The following is a description of a gene set: from publication Szanto A, Balint BL, Nagy ZS, Barta E, Dezso B, Pap A, Szeles L, Poliska S, Oros M, Evans RM, Barak Y, Schwabe J, Nagy L (PMID 21093321) studied in species Homo sapiens Genes up-regulated in bone marrow-derived macrophages with STAT6 knockout treated with rosiglitazone: control versus IL4. C57Bl/6 wild-type and STAT6 KO mice were used to study PPARg and IL-4 signaling. Bone marrow of 3 mice per group was isolated and differentiated to macrophages with M-CSF (20 ng/ml). 20 ng/ml IL-4 was used to induce alternative macrophage activation and 1 uM Rosiglitazone (RSG) was used to activate PPARg. From each mouse 4 samples were generated: 1. M-CSF, 2. M-CSF+RSG, 3. IL-4 and 4. IL-4+RSG. All compounds were added throughout the whole differentiation process, and frech media was added every other day. Control cells were treated with vehicle (DMSO:ethanol). After 10 days, RNA was isolated and gene expression profiles were analyzed using Mouse Genome 430 2.0 microarrays from Affymetrix. Human Gene Set: GSE25088_ROSIGLITAZONE_VS_IL4_AND_ROSIGLITAZONE_STIM_STAT6_KO_MACROPHAGE_DAY10_UP, and this is the list of marker genes: PGAP6, SYK, TLE4, PARP16, TGFBR2, CAMK1D, ENSG00000284948, CLCN4, PGGHG, KMT2D, ARHGAP19, FKBP8, DNAAF11, DGCR2, HAL, TBXAS1, ARSG, BAZ2B-AS1, REPS2, TRAPPC14, FOLR1, PAIP2, TBC1D10C, RAB43, H2AC11, FURIN, AOC3, YPEL5, TMEM91, UBXN2B, NUP50, ZDHHC18, MAP3K1, VSIR, ZFP36L2, RAF1, RNF44, TNRC18, RYBP, TIMP2, RNASE2, WIPI2, TAGLN2 (NCBI Gene Id 8407), MTMR3, CCDC28A, PPP1R12A, IFITM2, TRIM25, STX16, IQGAP1, DEF8, NFAM1, NHSL2, F5, NT5C3A, GNAS, MAPK1, ADGRE3, TLR8, CELF2, MARF1, SMARCA2, TRPM6, NCOA4, DEF6, TOB2, PCMTD1, LRCH4, TRERF1, TAOK3, TNRC6B, MAP3K2, PPP1R12B, ZNF93 (NCBI Gene Id 81931), NAIP, ARAP3, KIT (KIT proto-oncogene, receptor tyrosine kinase), RUBCNL, ZNF641, XKR8, KRT23, MTURN, SCAP, ARPC5, TMT1A, HYCC2, NDEL1, GLIPR1, MAN2A2, SNX18, LAMTOR4, PADI4, RXRB, NATD1, FHIP2A, PHF21A (NCBI Gene Id 51317), MKRN1, RAP1GAP2, GPAT3, COTL1, CHMP1B, HDAC5, GDE1, MCTP2, SLC25A37, GNAI2, PPP2R5C, CLC, H2AC14, CAMP, H2BC6, CIC, WWC3, TMX4, ACTN2, CX3CR1, H2BC12L, PRCP, RAB11FIP1, NDUFB3, DOCK8, AGTPBP1, AKT1 (NCBI Gene Id 207), TRMT5, TBC1D1, FCGR3B, RPGRIP1, TRANK1, PHF2, RCOR1, NPEPPSP1 (NPEPPS pseudogene 1), ULK1, C15orf39, OSTF1, MAP3K5, RAB37, PYCARD, MICAL2, GDPD3, HHEX, ZRANB1, NRBF2, SYNE2, ABTB1, BNIP3L, MED13L, GPSM3, CYP4F3, ST3GAL2, ADGRE2, TMEM164, NCF1C, PDZD8, FOSL2, MSRB1, YIPF3 (NCBI Gene Id 25844), IRS2, CYTH1, CEACAM3, SLMAP (NCBI Gene Id 7871), CBX1, NEK7, FGD3, FAR1, MRTFA, PTPRC, CMTM1, HBP1, MRFAP1L1, DGAT1, COP1, ARHGAP30, CYRIA, VNN3P, BAZ2B, HIPK1, ACTN1, MTMR10, KLHL2, BICD2, RTN3, UBE4B, NSD3, MANSC1, APLP2, PADI2, PTEN, NUDT5, NSFL1C, SPOPL, C8orf88, WDFY2, RBM5, C11orf21, BOD1L1, FKBP9, NIN, IL4R